Given this list of marker genes GSN, BID, PRKAA2, RB1, KRT8, ATF2, ARF6, KRT18, PIK3CG (NCBI Gene Id 5294), BCL2L1, PRKAA1, CASP6, STK4, STK3, PPARA, MIR675, MTCH2, CFLAR (NCBI Gene Id 8837), DNMT3A, ADAR, here is a description of the gene set: Human Gene Set: GOBP_HEPATOCYTE_APOPTOTIC_PROCESS Any apoptotic process in a hepatocyte, the main structural component of the liver. studied in species Homo sapiens